The following is a description of a gene set: Genes predicted to be targets of miRBase v22 microRNA hsa-miR-20b-5p in miRDB v6.0 with MirTarget v4 prediction scores > 80 (high confidence targets). from publication Chen Y, Wang X (PMID 31504780) studied in species Homo sapiens Human Gene Set: MIR20B_5P, and this is the list of marker genes: BTBD10 (NCBI Gene Id 84280), PCDHA7, NR2C1, RAB8B, ACSL4, ZNF148, CENPQ, FSD1L, MAP3K2, RUFY2, SPOPL, ITGA4, MTF1, SIKE1, PTPRD, FGD4, SLC33A1, BHLHE41, ZBTB21, ZFYVE26, ST3GAL1, RAPH1, SNX16, SLC24A2, CALD1, SMOC1, ARHGEF11, KMT2B, STAT3, KIF26B, GNPDA2, ABHD2, ETV1, NTN4, LAMA3, CCND1, NAA30, MKNK2, BTG3, PLAG1, RBM12B, NBEA, SERP1, CAPN15, DNAL1, THRA, STRIP2, LDLRAP1, HEG1, GXYLT1, BEST3, LHX6, LIMK1, ANKRD13C, SLC46A3, ARHGEF28 (Rho guanine nucleotide exchange factor 28), ANKH, EPS15L1, NEUROG1, ULK1, CHRM2, MAGI3, SLC4A4, ELK4, LIMA1, FCHO2, WDFY2, PITPNA, HIF1A, ARHGAP26, OSM, CNOT4, AKTIP, ZNF236, NPAT, DAB2, ABL2, ATP12A, MCL1, LRPAP1, NAGK, TMEM168 (transmembrane protein 168), GABBR2, MAPRE3, KIF23, PURB, CERCAM, STXBP5, NFIC, BCL11B, MTMR3, USP28, RBL1, ANO6, UBXN2A, ATL3, LDLR (NCBI Gene Id 3949), IQSEC2, USP3, SEPTIN2, RUNX3, HPS5, PLXNA1, TET1, JPT1, CEP97, STK11, FBXO48, NDEL1, LCOR, FAM210A, E2F1, CAMTA1, SCAMP2, DERL2, LMO3, CREB1, RASL11B, PPP6C, XRN1, IRF1, REST, SRPK2, TRAPPC14, GOLGA1, HAS2, EGLN3, ZBTB18, BBX, ERAP1, SMAD4, PDE3B, TMEM265, SLITRK3, LAPTM4A, ABCG4, DENND5B, EFCAB14, PCDHA6, VASH2, MASTL, MAPK1, DNAJC16, SLC22A23, PCDHA5, F3, GOSR1, SERF1B, CAPRIN2, CHP2, CD69, P2RX4, CLOCK, OLFM3, RNF128, USP46 (NCBI Gene Id 64854), TPRG1L, PTGDR, FAT2, RLIM, ERC1, CYBRD1, NTNG1, SMAD5, DOCK4, TSG101, PCDHA1, GUCY1A1, MAP3K8, FEM1C, SUCO, TIAM1, STK17B, SLC40A1, MFSD8, ARID4A, PSD, BAHD1, AKAP13, PTPN3, SNTB2, CEP120, ITGB8, PDCD1LG2, VANGL1 (VANGL planar cell polarity protein 1), PXK, HAUS8, DENND10, SYTL4, NFAT5, PLXDC2, ANKRD52, FAM219B, KLF9, ABI1, GRAMD1A, WNK3 (WNK lysine deficient protein kinase 3), ATG16L1, BMPR2, PANX2, FAT4, ZNF202, NIPA1, MFAP3L, LASP1, ZSCAN20, RAB30, ANKRD17, SFMBT1, ZFP91, USP32, WFS1, IRF9, MAP3K9, PKD1, ARHGAP12, ZNF597, NEDD4L, APCDD1, PRR15, SH3BP5 (NCBI Gene Id 9467), PTPN21, ZNF827, RACGAP1, NR2C2, UNC80, PCDHA2, PCDHA3, USP24, REV3L, BCL2L11, CMPK1, PCDHA12, TAGAP, RBBP7, TANC1, ORMDL3, C14orf28, RAPGEFL1, TGFBR2, FAM199X (NCBI Gene Id 139231), NPLOC4, PLAGL2, TNFRSF21, KCNB1, SERTAD2, EIF4A2, BICC1, CMKLR1, MYO5B, ZXDA, PXYLP1, TGM2, FYCO1, TMEM127, HTR2A, EIF5A2, DNAJC27, TAOK3, OXR1, UBE2Q2, EEIG1, TAFA1 (TAFA chemokine like family member 1), ZBTB41, CMTR2, TMEM167A, PRRG1, TAOK1, PFKP, SPRED1 (sprouty related EVH1 domain containing 1), CD274, ARHGEF3, ISM2, ZNF800, SESN3, MCF2L, PBX3, ATXN1L, NFIB, RBL2, PIK3R1, NCOA3, LYPD6, AGTPBP1, RB1CC1, FBXL3, FJX1, KLHL15, PTPN4, TNFAIP1, ARHGAP1, SNX8, PGBD5, KIAA0513, CNOT6L, FRS2, FNBP1L, RNH1, AHNAK, RASGRF2, PTHLH, FBXO21, RPS6KA6, TRDN, CTSK, DDX5 (NCBI Gene Id 1655), U2SURP, ST6GALNAC6, RETREG2, SOS1, KMT5B, SLC16A6, TXNIP, ZNFX1, TNKS2, PPP1R3B, KCNJ10, EPHA5, PEX5L, UEVLD, ZBTB33, ZBTB20, TET3, PKD2, MAP3K14, RHOC, VLDLR, ZNF652, SOX4, NABP1, CNOT6, E2F5, ZNF367, CREB5, LRIG1, SEMA4B, AKAP11, TRPV6, ANKIB1, NIBAN1, KLHL2, RAB11FIP1, IGSF10, KMT2A, ZNF512B, GPR6, SALL3, MFN2, PCDHA4, RSRP1, TMEM138, SQSTM1, FOXJ3, STK38, YOD1, UNK (unk zinc finger), AAK1, ZNF264, UXS1, DDHD1, ZBTB9, RGMB, RPS6KA4, KLHL28, SSH1, TMBIM6, EREG, RGL1, DYNC1LI2, UBE3C, HBP1, URI1, RNASEH2B, SERF1A, ANKRD29, RNF6, TM2D2, DRD1, PAG1, RAB11FIP5, ZBTB4, LRRC55, L3MBTL3, PCDHA11, MYNN, RORA, AGO1, ZDHHC1, OSTM1, MMP24, REPS2, CNOT7 (NCBI Gene Id 29883), C2CD2, KIAA1191 (KIAA1191), TRIP10, TNKS1BP1, IL6ST, CDC37L1, ITPRIPL2, APP, BNC2, RETREG3, ARHGEF18, STYX, HECTD2, PRR14L, ELK3, CDC23, SSX2IP, SSH2, ANKRD33B, MOSMO, TMX3, B3GALT2, CHD5, ENTPD4, ZNF704, TSPAN9, CRY2, EMSY, GPATCH2, SMOC2, PGM2L1, HYCC2, MAP7, NCKAP5, SAR1B, OSR1, ZFAND4, TRIP11, OTUD4, GNB5, PFKFB3, CLIP4, PCDHA13, BRMS1L, FRMD6, ARMC8, KPNA2, PRCP, NIN, KLF11, MARCHF8, SLC17A7, CXCL6, PAK5, NRIP3, DUSP2, PDLIM5, USP31, MED12L, KIF3B, MAPK4, ZNF280B, GPR63, EPHA4, TRIM37, NACC2, ZC3H12C, HLF, ROCK2, PSG3, C2orf69, TP73, FBXL5, FLT1, FBXO31, SH3PXD2A, DCUN1D1, CROT, IL1RAP, LPGAT1, MYLIP, BTN3A1, CRYBG3, DPYSL2, CSRNP3, AMER2, PRR16, HS3ST5, ANKFY1 (ankyrin repeat and FYVE domain containing 1), SCAMP5, FAM13A, PAPOLA, SLC16A9, EZH1, PRDM6 (PR/SET domain 6), ZNF25, TMEM64, SGMS1, SEMA7A, AP2B1, FGD5, ENTREP2, SLMAP, RAB10, PPP3R1, ARHGEF10, MKRN1, PDGFRA, ZHX2, KCNK10, SACS, GNS, BICD2, RGMA, PHIP, LRP8, TENM1, ADARB1, PCDHAC1, TBC1D8B, TBC1D20, ANKRD50, CFL2, ARID4B, MYT1L, RPS6KA5, SRCIN1, SLAIN2, LYST, CNRIP1, PARD6B, SUSD6, MAP10, NPAS2, CC2D1A, OCRL, SAMD12, ABCA1, FZD3, RAB22A, NUP35, MINK1, ZFYVE9, TOPORS, CEP170, SRGAP1, PCDHA8, EPHA7, TRIM3, MEX3D, USP6, DUSP8, RORC, PPP1R21, GPR137C, KAT2B, LRCH1, UNKL, NANOS1, S1PR1, TFAM, NKIRAS1, DPYSL5, AGFG1, SLC4A8, VSX1, PLEKHA3, PAPOLB, RRAGD, PPP1R15B, ADAM9, WDR37, BNIP2, ZBTB7A, PTPDC1, FNDC3B, PCDH15, DNAJB9, DCBLD2, SCN1A, ENPP5, RAB5B, NAPEPLD, SLC49A4, FAM13C (NCBI Gene Id 220965), ZFPM2, SCN2B, CORO2B, BRWD1, ZBTB8A, PCDHA10, PHC3, RRAS2, GPR137B, WDFY3, ZDHHC9, ATG2B, EGR2, NHLRC3, RAP2C, AGFG2, SALL1, CTSA, KATNAL1, CCDC71L, FAM117B, REEP3, RCCD1, ATAD2, AFG1L, RASD1, HSPA8, RRM2, GAB1, FOXK2, TBC1D9, TMEM100, BTBD7, LZIC, PCDHAC2, MIDN, TRIM36, CCNG2, GLIS3